The following is a description of a gene set: Mouse Gene Set: GOBP_NEURON_PROJECTION_GUIDANCE studied in species Mus musculus The process in which the migration of a neuron projection is directed to a specific target site in response to a combination of attractive and repulsive cues., and this is the list of marker genes: Matn2 (NCBI Gene Id 17181), Lhx4, Dscam, Foxd1, B3gnt2, Nptn, Cntn1, Nr4a3, Cntn6, Prtg (NCBI Gene Id 235472), Chl1, Runx3, Vax1, Ntrk1, Efnb1, Epha10, Ntn5, Lhx3 (NCBI Gene Id 16871), Sema6c, Slit2, Lama1, Cyfip1, Vangl2, Tgfb2, Klf7, Zic2, Ulk1, Ryk, Fgf8, Edn1, Rpl24, Mir200a, Emb, Or10a4, Dscaml1 (DS cell adhesion molecule like 1), Gfra3, Ncam1, Scn1b, Myot, Rac1, Mef2c, Ptpro, Ephb2, Diaph1, Flot1, Lamc1, Agrn, Gap43, Unc5c, Dcc, Epha8, Robo1, Ablim1, Sema6a, Gdf7, Bcl11b, Kif5a, Plxna3, Unc5a, Mir9-2, Nrp2, Myh10, Boc, Evl, Sema3e, Isl1, Dpysl5, Atoh7, Bsg, Ythdf1, Arhgap35, Robo3, Egr2, Otx2, Ptprm, Or8a1b, Gli2, Ephb3, Lamb2, Wnt3, Csf1r, Alcam, Cdh4, Lamc3, Chn1, Sema5b, Sema4a, Apbb2, Gbx2, Celsr3, Nrp1, Ptprh, Nrcam, Ntf3, Foxp1, Evx1, L1cam, Dag1, Efna2, Mir9-3, Flrt3, Lama3, Sema4g, Diaph2, Bmpr1b, Epha6, Vasp, Wnt7b, Sema3c, Neo1, Lhx1, Mir200c, Efnb2 (ephrin B2), Sema4c, Lmx1a, Arx, Ptprj, Mir9-1 (NCBI Gene Id 387133), Sema5a, Vegfa, Epha3, Sema4b (sema domain, immunoglobulin domain (Ig), transmembrane domain (TM) and short cytoplasmic domain, (semaphorin) 4B), Ext1, Nfib, Flrt2, Lgi1, Dlx5, Lmtk2, Epha4 (NCBI Gene Id 98323), Efna4, Mapk8ip3, Ntn1, Ednra, Hdac6, Lgr4, Hoxa2, Neurog2, Cntn2, Crppa, Ndp, Sema7a, Ptprv, Isl2, Lama5, Sema4d, Ephb1, Efnb3, Rtn4r, Mnx1, Pcdhac2, Usp33, Plxna1, Cdk5r1, Nkx2-1, Cxcl12, Epha7, Gata3, Nog, Pou4f2, Tubb3, Smad4, Apbb1, Nfasc, Kif5b, B4gat1, Sema4f, Ece1, Fezf2, Shh, Edn3, Gbx1, Bmp7, Kalrn, Foxg1, Pou4f3, Wnt5a, Trio (NCBI Gene Id 77730), Notch3, Sema3d, Sema6b, Epha5, Lmo4, App, Sema3a, Dvl1, Ark2c, Atoh1, Cyfip2, Ttc8, Efna3, Draxin, Igfals, Fezf1, Plxna4, Unc5b, Robo2, Rtn4rl1, Nell2, Artn, Megf9, Gli3 (NCBI Gene Id 14634, GLI-Kruppel family member GLI3), Mypn, Tbr1, Efna5, Ulk2, Etv4, Mir200b, Smo, Enah, Cntn5, Sema6d, Cdk5, Rac3, Pax6, Lamb1, Tubb2b, Lrp1, Ntn3, Hoxa1 (homeobox A1), Megf8, Sema3f, Etv1, Cdk5r2, Ptch1, Ngfr, Mir376a, Sema3g, Nexn, Reln, Sema3b, Kif21a, Lhx2, Slit1, Mycbp2, Efna1, Lrp2, Bmpr2, Kifc2, Drgx, Adam17, Notch1, Ank3, Gas1, Nova2, Ntn4, Lamb3, Lhx9, Unc5d, Slit3, Pla2g10, Lamc2, Lama2, Gdnf, Nectin1, Arhgef25, Wnt3a, Erbb2, Fzd3, Cxcr4, Ephb6, Kif5c, Bdnf